Given this list of marker genes PRKAG2, THRSP, MID1IP1, RXRA, CPT1B, SLC25A20, PPARD, PRKAB2, CPT1A, ACACB, PRKAA2 (protein kinase AMP-activated catalytic subunit alpha 2), ACACA, SLC22A5, CPT2, here is a description of the gene set: Human Gene Set: REACTOME_CARNITINE_SHUTTLE Carnitine shuttle studied in species Homo sapiens